Given this list of marker genes CXCL8, BLM, PCNA, ORC3, TOPBP1, POLD1, CD28, MCM5 (NCBI Gene Id 4174), CENPF, MCM2, REV1, MCM7, FEN1, TEP1 (NCBI Gene Id 7011), NAP1L1, CRYAB, ORC2, POLG, LIG4, UBE2A, POLB, PURA (purine rich element binding protein A), CDC45, IGF1, PPP2CA, KAT7, LIG1, CHRAC1, RPA1, POLN, MCM3AP, PPP2R1B, CXCR6, TYMP, CHAF1A, POLL, LAMTOR5, CENPE, TMX1, POLD4, TREX1, RFC4, TERT, CCL4, POLI, CDC7, MCM3, POLA2, HTATSF1, ACHE, PRIM2, RAD9A, RFC1, CCL2, LIG3, NFIA, CDC34, CCL3, ORC1, ABCF2, MCM6, BRCA1, ORC6, CDC6, CLEC4M, CDK2AP1, REPIN1, TNIP1, POLE2, RFC3, UBE2B, S100A11, DNTT, UBP1, NFIC, MCM8, PPP2R3B, DEK, TFAM, PPIA, ORC4, PTTG3P, PTTG1, WDR33, POLE4, IGHMBP2, PPP2CB, PTTG2, RFC5, GINS2, MCM9, POLQ, RPA2, SUPT5H (SPT5 homolog, DSIF elongation factor subunit), RPA4, CDK2, REV3L, CHTF18, RRM1, SMC2, RPA3, SET, POLD3, RFC2, TOM1L2, RBM14, RAD17, EGF, RBBP4, TENT4A, SMC1A, CD209, POLA1, TSPYL2, POLE3, PPP2R1A, POLD2, RBMS1, DUT, SUV39H1, SMC3, POLM, NFIB, EIF5A, NFIX, PTMS, PNKP, MSH2, MCM4, SSBP1, GMNN, RRM2, ORC5, CTBP1, POLG2, WRNIP1, NT5M, CTBP2, POLH, POLRMT, SMC4, UBA1, OPRK1, NCOA6, CHAF1B, MYBBP1A, here is a description of the gene set: Genes involved in DNA replication, compiled manually by the authors. from publication Kauffmann A, Rosselli F, Lazar V, Winnepenninckx V, Mansuet-Lupo A, Dessen P, van den Oord JJ, Spatz A, Sarasin A (PMID 17891185) studied in species Homo sapiens We have identified a gene-profile signature for human primary malignant melanoma associated with metastasis to distant sites and poor prognosis. We analyse the differential gene expression by looking at whole biological pathways rather than individual genes. Among the most significant pathways associated with progression to metastasis, we found the DNA replication (P=10(-14)) and the DNA repair pathways (P=10(-16)). We concentrated our analysis on DNA repair and found that genes of this category, among a list of genes, are associated with metastatic progression. These genes belong essentially to the pathways allowing recovery of stalled replication forks due to spontaneous blockage or induced DNA lesions. Because almost all these differentially expressed repair genes were overexpressed in primary tumors with bad prognosis, we speculate that primary melanoma cells that will metastasize try to replicate in a fast and error-free mode. In contrast to the progression from melanocytes to primary melanoma, genetic stability appears to be necessary for a melanoma cell to give rise to distant metastasis. This overexpression of repair genes explains nicely the extraordinary resistance of metastatic melanoma to chemo- and radio-therapy. Our results may open a new avenue for the discovery of drugs active on human metastatic melanoma. Human Gene Set: KAUFFMANN_DNA_REPLICATION_GENES